Given this list of marker genes Ywhaz, Stk25, Pdcd10, Vcpip1, Vps13b, here is a description of the gene set: studied in species Mus musculus Mouse Gene Set: GOBP_GOLGI_REASSEMBLY The reformation of the Golgi following its breakdown and partitioning contributing to Golgi inheritance.